Given this list of marker genes PYCR1, LTBP1, AEBP1, FBLN5, ATP6V1E1, here is a description of the gene set: Premature sagging cheeks studied in species Homo sapiens Human Gene Set: HP_PREMATURE_SAGGING_CHEEKS Drooping or sinking of tissues of the cheeks more than would be expected at a given age. Sagging can occur due to a relative excess of skin and/or lack of elastic recoil as well as fat accumulation.